The following is a description of a gene set: Voltage gated Potassium channels species: Homo sapiens Human Gene Set: REACTOME_VOLTAGE_GATED_POTASSIUM_CHANNELS, and this is the list of marker genes: KCNC4, KCNC1, KCNG1, KCNH3, KCNA1, KCNS1, KCNB1, KCNS3, KCND3, KCNS2, KCNA4, KCNA3, KCNH2, KCNH4, KCNV1, KCNAB1, KCNAB2, KCNC3, KCNH6, KCNB2, KCNA6, KCNV2, KCNH1, KCNA7, KCNH5, KCNQ2, KCNF1, KCNG3, KCNH7, KCND2, KCNQ1, KCNQ5, KCNA2, KCNQ4 (potassium voltage-gated channel subfamily Q member 4), KCNA5, KCNG4, KCNA10, KCNAB3, KCNH8, KCNQ3, KCNG2, KCND1, KCNC2